Given this list of marker genes HNRNPA2B1 (NCBI Gene Id 3181), MT2A, ATP5F1B, RPL35, HECTD1, ST6GAL1, LAPTM4A, CLCNKB, RPL24, RPS18, RALBP1, MPP7, SARAF, KRT18, EEF1A1, IDH2, MYL6, EIF3K, ARHGEF28, PRDX1, UQCRFS1, C12orf75, DSP, TGOLN2, RPS20, LAMTOR5, TPT1, PRKAR1A, ATP6V1A, KMT2E, H3-3B, CYSTM1, RPL13A, CD63, ARF1, MBOAT2, ATP6AP2, RPS25, ADGRG1, HINT1, RPS28, MAP1LC3B, PRDX6, MOB1B, HSPD1, NDUFA4, RPL19, EZR, RSRP1, HSP90B1, DHRS7, CIAO2B, RPL7, YWHAB, HSPA4, BTF3, HLA-C, CRYAB, RPL4, RPS9, RPL41, ACTR2, PSAP, ARL6IP5, NRDC, CHCHD10, RPL31, SPTBN1, RASD1, CALM1, ATP6V0A4, ZDHHC3, S100A10, REEP5, DYNLT1, RPL34, MAL, RPS23, FUBP1, ATP5F1A, FAU, ARHGAP5, MYL12B, CYCS, PDIA6, PGK1, ARHGAP18, NDUFA5, MARCHF1, ANAPC16, SNTB1, RACK1, RANBP2, RPS6, ANXA2, EPS8, RPL15, TAF7, MPPED2, NACA, HNRNPR, TXNRD1, PAPOLA, RPLP2, IGFBP7, RTN4, PTGR1, LIMA1 (LIM domain and actin binding 1), RPL9, RCAN2, LITAF, HNRNPU, ATP6V0E1, ACTG1, MYL12A, MSMO1, PRPF40A, SLC16A5, GPBP1, TFCP2L1, PNPLA8, CNN3, ATP6V1G1, RPSA, RPL11 (NCBI Gene Id 6135), ATP5F1C, RPS2, NORAD, APP, TAX1BP1, NAMPT, GHITM, WWP1, FTL, SAT1, PTGER3, SLC4A1, EEF2, RPLP1, EPRS1, ITGA6, SOD2, SERBP1, TMEM117, ACAT1, CD164, COX7C, CD59, CD9, NFE2L2, PKM, GPX1, FDFT1, TSPAN1, PSMA7, COX5B, SERF2, ZFAND5, RPS4X, RPL23, CRYBG3, RETREG1, CAPN2, CCT6A, PDIA3 (NCBI Gene Id 2923), RPL30, PTTG1IP, RPS13, CD74, GABARAPL1, HSPA9, HSPH1, RPS24, GAPDH, APLP2, ALDOA, CBR1, PTGES3, TMEM213 (NCBI Gene Id 155006), CSDE1, RPS12, RPL8, HSPB1, FTH1, TMF1, H1-0, RBBP8 (RB binding protein 8, endonuclease), UBE2D3, MTR, RPL32, RPS3 (NCBI Gene Id 6188), RPS11, SNX3, LDHB, RPS8, HADHA, SF3B1, HADHB, PGGHG, HSP90AA1, CALCA, SKP1, RPS15, EIF4A2, XRCC5, GRB14, CLU (NCBI Gene Id 1191), RPL21, CD46, SLC25A5, TMPRSS2, HSPA5, ISCU, RPS17, SCIN, GSTP1 (NCBI Gene Id 2950), SRP14, UBXN4, CA2, PEBP1, ATP1B1, SEC62, CD24 (CD24 molecule), TACSTD2, PPIA, PLOD2, NCOA7, TMEM123, RPL12, RPL35A, SLC38A1, AKR1C1, CA12, ATP6V0B, RPS5, ERP27, STAP1, RPS3A, LINC01187, BMPR1B, AQP2, RPL10A, HSPA4L, GNAS, SEPTIN11, RPL14, TMEM59, HLA-B, RPS14, MTATP6P1, ATP5PB, INSIG1, RPS19, ATP5MC3, COX4I1, ATP6V0D2, CUL5, ENO1, TPI1, GAS5 (NCBI Gene Id 60674), B2M, LDHA, SOD1, SPTBN2, LGALS3, RPL13, FOXI1, EPCAM, SNHG29, CNBP, DYNLT3, TMBIM6, RPS27A, WFDC2, DDX5, EIF1, MDH1, RPS16, PCBP1, IL18, TERF2IP, RPS7, PHLDB2, PAFAH1B1, RHCG, EID1, VAPA, ADGRF1, UBB, SELENOW, CDH16, NPM1, TBC1D14, RPL3, FYB2, CANX, RPL37A, RHOA, SLC26A7 (NCBI Gene Id 65015), SLC25A39, PFDN5, RPL6, KIF5B, PTBP3, CHCHD2, KIT, HSP90AB1, RPL5, TM9SF3, DMRT2, SLC25A3, RPLP0, JAK1, RPL18, ALDH1A1, BTG1, RPL7A, CYB5A, ITM2B, CLIP1 (NCBI Gene Id 6249), COX5A, RPL10, CIB1, TMSB4X, TXNIP, RPS27, here is a description of the gene set: from publication Lake BB, Chen S, Hoshi M, Plongthongkum N, Salamon D, Knoten A, Vijayan A, Venkatesh R, Kim EH, Gao D, Gaut J, Zhang K, Jain S (PMID 31249312) Human Gene Set: LAKE_ADULT_KIDNEY_C19_COLLECTING_DUCT_INTERCALATED_CELLS_TYPE_A_MEDULLA species: Homo sapiens